Given this list of marker genes KREMEN2, WNT3A, WIF1, LRP6, DKK4, DKK1, SFRP1, WNT9A, SFRP2, KREMEN1, SOST, WNT5A, DKK2 (dickkopf WNT signaling pathway inhibitor 2), LRP5, WNT4 (Wnt family member 4), here is a description of the gene set: Negative regulation of TCF-dependent signaling by WNT ligand antagonists species: Homo sapiens Human Gene Set: REACTOME_NEGATIVE_REGULATION_OF_TCF_DEPENDENT_SIGNALING_BY_WNT_LIGAND_ANTAGONISTS